Given this list of marker genes Sstr2, Tbxa2r, Ackr2, Insl3, Lpar4, Sst, Ppy, Ccr8, Prok2, C5ar2, Ccl21d, Rxfp2, Drd4, Tacr1, Uts2b, Nmur2, Ccl27al, Cxcl1, Tac2, Oprl1, Nmb, Gng11, Ramp3, Grm7, Adra2a, Tas2r126, Ccr5 (C-C motif chemokine receptor 5), Ackr3, Gpr132, F2r, Pth2, Gprc6a, Nms, S1pr1, Htr1b, Fshb, Crhbp, Mtnr1b, Tas1r2 (NCBI Gene Id 83770), Tas2r130, Npy, Ffar1, Nps, Gnb2, Taar8b, Chrm5, Qrfprl, Adgre1, Ccl12, Grp, Gabbr1, Cmklr1, Grm4, Lpar2, Gng8, Gnb1, Grm8, Ptgdr2, C5ar1, Tas2r120, Tas2r138, Gpr18, Hebp1, Gnb3, Taar6, Rxfp3, Cck, Lhcgr, Plppr4, Ccl4, Htr4, Vip, Adm2, Cxcr3, Lpar6, Tshb, Adm, Pyy, Ucn, Ccl1, P2ry2, App, Iapp, Ccl5, Rln3, Tas2r139, Ccl28, Prlh, Ccl20, Mc1r, Cxcl5, Anxa1, Gpha2, Oxt, Pth, Eef1ece2, Gpr37, Tas2r136, Nts, Tas2r131, Cxcl11, Tas2r121, Avpr1a, Ffar2, Calcb, Gnrhr, Adora2a, Galr1, Hrh4, Gnrh1, Galr3, Gnb4, Ednra, Hrh1, Tshr, Ptgdr, Npsr1, Hrh2, C3, Lpar5, Calca, Ackr4, Edn1, Grm5 (glutamate receptor, metabotropic 5), Cnr2, Cysltr1, Glp1r, Ccl9, P2ry6, Fpr-rs4, P2ry14, Ucn2, Taar8c, Gpr4, Ptgfr, Gpr55, Htr7, Ucn3, Gpbar1, Ccl21a, Apln, Grm3, Gnas, Tacr3, Pmch, Ptger2, S1pr4, Chrm1, Avp, Tas1r3, Cxcl16, Taar3, Mc5r, Adcyap1r1, P2ry13, Ccl21e, Kng2, Cxcr4, Nln, Taar2, Htr5a, Hrh3, Kiss1, Rln1, P2ry10, Trhr, Ramp2, Trh, Ptger1, C3ar1, Fpr2, Uts2r, Ptger3, Crhr1, Agtr2, Ltb4r1, Edn2, Uts2, S1pr3, Plppr5, Crh, Gng7, Plppr2, Edn3, Fpr1, Gpr37l1, Hcar2, Tas2r144, Sctr, Ccr9, Chrm3, Cxcl13, Cxcr5, Gpr31b, Adrb3, Adora3, Gphb5, Hcrtr1, Ppbp, Npff, Prokr2, Hcrtr2, Mtnr1a, Drd5, Tas2r140, Drd3, Kel, Gpr17, Ccl6, Mchr1, Gpr65, Htr1f, Gpr183, Sstr4, Ccl22, Npffr2, Ccl17, Ccl21b, Ccr4, Gng5, Adgre5, Pdyn, Cxcl9, Prok1, Tas2r118, Gpr35, Ramp1, Pth1r, Rxfp4, Ccl27b, Adrb1, Cxcl10, Adrb2, Cnr1, Tas1r1, Vipr2, Oxgr1, Kiss1r, Nmur1, Htr6, Cckar, Opn1mw, Htr1a, Ece1, Tas2r119, Sct, Aplnr, Ltb4r2, Rgr, Rrh, Grpr, Xcl1, Npb, Pf4, Ffar3, Pthlh, Hcrt, Bdkrb1, Nmu, Ptafr, Htr1d, Oprk1, Ntsr1, Bdkrb2, Ccl3, Pomc, S1pr5 (NCBI Gene Id 94226), Plppr1, Cx3cr1, Cxcr2, Gip, Gpr143, Npy1r, Nmbr (neuromedin B receptor), Mc4r, Gng3, Opn3, Galr2, Rxfp1, Psap, Oprm1, Cxcl3, Chrm2, Gng12, Mc2r, Opn1sw (opsin 1 (cone pigments), short-wave-sensitive (color blindness, tritan)), Hcar1 (hydrocarboxylic acid receptor 1), Adcyap1, Cd55, Npffr1, Adra1b, Agt, Npy5r, Vipr1, P2ry12, Gal, Ccr7, Oprd1, Sucnr1, Taar1, F2, Brs3, Mc3r, Cx3cl1, Cckbr, Chrm4, Lhb, Npw, Lpar1, Hc, Cxcl2, Npy2r, Drd2, Tacr2, Prokr1, Gng13, Htr2c (5-hydroxytryptamine (serotonin) receptor 2C, NCBI Gene Id 15560), Plppr3, Gng10, Cxcl12, Ccl21f (C-C motif chemokine ligand 21F), Gper1, Grm1, Ptgir, Gngt2, Gpr68, F2rl3, Fpr-rs3, Adra1a, Casr, Ccl27a, Crhr2 (NCBI Gene Id 12922), Tas2r106, Penk, Adora1, Pth2r, P2ry4, Sstr3, Fpr-rs7, Adora2b, Sstr5, Ednrb, Cysltr2, Ghrhr, Ccl19, F2rl2, Grm2, Cort, Tas2r137, Gngt1, Fpr-rs6, Ntsr2, Gabbr2, Cxcr1, Glp2r, Ccl11, Npy4r, Tas2r135, S1pr2, Insl5, Avpr2, Opn5, Grm6, Calcrl, Sstr1, Gcg, Lpar3, Pnoc, Drd1, Tas2r108, Ece2, Xcr1, Tac1, Ccr3, Gnb5, Ccr10, Fpr3, Oxtr, Gipr, Opn4, Calcr, Gcgr, Adra2b, Qrfp (NCBI Gene Id 227717), Cxcr6, Taar5, Ccl25, Cga, Xk, Adra2c, Fshr, Gng4, Ccrl2, Rho, Htr2b, Npbwr1, Avpr1b, F2rl1, Htr2a, Adra1d, Gpr39, Prlhr, Taar9, Ccr6, Agtr1a, Ghrh, P2ry1, Ptger4, Gng2, here is a description of the gene set: Mouse Gene Set: REACTOME_GPCR_LIGAND_BINDING GPCR ligand binding studied in species Mus musculus